The following is a description of a gene set: Mouse Gene Set: GOBP_POSITIVE_REGULATION_OF_CELL_JUNCTION_ASSEMBLY Any process that activates or increases the frequency, rate or extent of cell junction assembly. studied in species Mus musculus, and this is the list of marker genes: Wnt4, Cfl1, Map4k4, Lims1, Itgb1bp1, Myh9, Lrrn1, Lrrtm2, Pik3r1, Tbx5, Oxtr, Syndig1, Gdf2, Abl1, Nlgn3, Nlgn1, Slitrk3, Nrxn1, Lrrtm4, Tpbg, Dlg4, Crb3, Amigo2, Dlg5, Sdc4, Lingo4, Adgrl1, Ephb2, Agrn, Fmn1, Lrrc4b, Bdnf, Enpp2, Iqgap1, S100a10 (S100 calcium binding protein A10 (calpactin)), Irx3, Ephb3, Adgrl2, Ube2v2, Rac1, Lrtm1, Ntrk3, Ppm1f, Col16a1, Thbs2, Adgrl4, Epb41l5, Ntrk2, Lrrtm3, Flrt2, Gsk3b, Il1rapl1, Lrrn3, Vegfa, Nlgn2, Cldn1, Sema4a, Ephb1, Grid2, Actr3, Lrtm2, Epha2, Thy1, Ace2, Slitrk6, Sema4d (sema domain, immunoglobulin domain (Ig), transmembrane domain (TM) and short cytoplasmic domain, (semaphorin) 4D), Cux2, Lrrtm1, Ptprd, Adnp, Myoc, Cldn3, Clstn1 (NCBI Gene Id 74323), Asic2, Bhlhb9, Cntnap2, Wnt7a, Fermt2, Il1rap, Slitrk1, Vstm5, Cbln2, Adgre5, Cbln1 (NCBI Gene Id 12404), Adgrb3, Lrrc24, Adgrl3, Slitrk4, Hrg, Cldn19, Agt, Xlr3b, Ptpn11 (NCBI Gene Id 72646), Stau2, Poldip2, Ghrl, Efna5, Oxt, Adgrb1, Ptprj, Il17a, Srpx2, Nphp4, Prkca, Clstn3, Flrt1, Amigo3, Musk, Hopx, Kdr, Rock1, Ntrk1, Cav1, Dsg3, Lingo2, Iqsec2, Tsc1, Cldn5, Acvrl1, Flot1, Slitrk2, Nphp1, Eef2k, Iqsec1, Adgrb2, Flrt3, St8sia2, Smad3, Slitrk5, Clstn2, Slit2, Tek, Amigo1, Nrp1 (neuropilin 1)